Given this list of marker genes GPM6A, PDPK1, SIK1, CDK2AP1, RAB11FIP5, ACSS2, DSN1, BMS1, CELA1, GNPDA1, FHIP2B, BCR, GSC2, KLRG2, COQ5, MAZ (MYC associated zinc finger protein), MUC20, ABHD3, SCP2, PRDX1, ABHD2, ID2, ALDH18A1, TMCO6, TFCP2, CENPO, HOMER3, CTDSP2, PPP1R8, REXO1, INO80D, METRN, CCNJ, MEF2D, CLCF1, YEATS2, SH3KBP1, LCLAT1, GADD45A, SREBF1, ANKMY2, TXN, PRUNE1, ING3, CHIC1, CYB5A, ZMAT3, ATIC, NBR1, FAM120AOS (family with sequence similarity 120 member A opposite strand), RNF187, MAP3K4, LENG8, PXN, CCDC127, ZBTB42, BLCAP, RHOQ, SLC17A3, GALNT1, TGM2, ACSL1, ZNF362, ADTRP, HDAC3, SLC25A46, BAG3, DHRS3, ABCA5, TNIP1, ZNF569, DHCR24 (24-dehydrocholesterol reductase), ZBTB4, TEX29, NAT2, TNFAIP2, CLUH, RINT1, POU2F3, D2HGDH, TENT4B, INPP1, FOXJ3, SH3D19, VPS13C, FGFR1, GTPBP2, SCRIB, ARFGAP2, CYB5R3, ANAPC7, ZC3H7B, TTF2, HMGXB3, CHST11, MTRR, EDRF1, PIGL, TPT1, TMEM164, C2CD2L, YWHAB, SLC36A1, ABHD12, TXNIP, SUGP2, PTK6, ZFYVE16, PLXNB3, ERCC4, FAM120A, GRN, INCENP, ANAPC5, VAV3, CREBL2, TMEM263, CTR9, USP42, ADGRE1, SGCB, ST6GALNAC6, MAGEE1, SUOX, JADE1, ZNF141, MYMK, ARHGEF4, ACADS, TTC13, GTDC1, RTN4RL1, E2F6, PTTG1IP, MINDY1, RNASEL, OXSM, ZMIZ2, KNOP1, ATG10, ASAH1, DNAJB1, CDH20, KHSRP, SEPTIN9, CPSF4, PPP3CC, ADGRL2, OSTM1, TRAF7, DUSP16, R3HDM4, NISCH, HIPK2, DNMT3B, OR5P3, SCARB2, CWC27, ZNF658, TRAPPC11, IFT70B, ERBB3, NHERF1, DCUN1D4, ANO6, U2AF1, MLLT11, ARID4A, MTFR1, COX11, ZFYVE27, VAMP5, SFMBT1, TMEM204, GLB1, GNAI2, YBEY, ACTR2, ADCY9, ACACA, RAB27A, ITGAX, MS4A7, AMPD2, ZFP36L1, ANGPTL4, PIP5K1C, NFKBIE, SORT1, FNDC1, MCM2, GRINA, ZNF467, R3HDM2, SRPK3, CD82, CDH6, BICRA, CBFA2T3, CEP41, here is a description of the gene set: Human Gene Set: GSE26030_TH1_VS_TH17_RESTIMULATED_DAY5_POST_POLARIZATION_DN Genes down-regulated in T helper cells 5 days post polarization and stimulated with anti-CD3 and anti-CD28: Th1 versus Th17. from publication Muranski P, Borman ZA, Kerkar SP, Klebanoff CA, Ji Y, Sanchez-Perez L, Sukumar M, Reger RN, Yu Z, Kern SJ, Roychoudhuri R, Ferreyra GA, Shen W, Durum SK, Feigenbaum L, Palmer DC, Antony PA, Chan CC, Laurence A, Danner RL, Gattinoni L, Restifo NP (PMID 22177921) Serial comparison between Th1 and Th17 tumor-specific cells cultured in vitro and ex vivo after transferred into sublethaly irradiated B6.PL mice. Th17-derived cells acquire Th1-like properties in vivo but maintain a distinct molecular profile. studied in species Homo sapiens